Given this list of marker genes Ccne1, Gadd45a, Sfn, Cnot4, E2f7, Ccna1, Tnks1bp1, Ccnb1, Npm1, Cdk1, Plk2, Cdkn1a, Pcna, Bax, Cnot10, Cdc25c (cell division cycle 25C), Cnot7 (CCR4-NOT transcription complex, subunit 7), Ccne2, Cdkn1b, Cenpj, here is a description of the gene set: species: Mus musculus part of: Transcriptional Regulation by TP53 This event has been computationally inferred from an event that has been demonstrated in another species.<p>The inference is based on the homology mapping from PANTHER. Briefly, reactions for which all involved PhysicalEntities (in input, output and catalyst) have a mapped orthologue/paralogue (for complexes at least 75% of components must have a mapping) are inferred to the other species. Reactome Pathway: TP53 Regulates Transcription of Cell Cycle Genes electronically inferred by orthology from the curated human pathway